The following is a description of a gene set: Mouse Gene Set: GOBP_GLOMERULAR_EPITHELIUM_DEVELOPMENT The process whose specific outcome is the progression of the glomerular epithelium over time, from its formation to the mature structure. The glomerular epithelium is an epithelial tissue that covers the outer surfaces of the glomerulus. The glomerular epithelium consists of both parietal and visceral epithelium. Metanephric glomerular parietal epithelial cells are specialized epithelial cells that form tight junctions as a barrier to protein transport. A metanephric glomerular visceral epithelial cell is a specialized epithelial cell that contains 'feet' that interdigitate with the 'feet' of other glomerular epithelial cells in the metanephros. species: Mus musculus, and this is the list of marker genes: Basp1, Prom1, Pdgfb, Nphs2, Foxj1, Nphs1, Ext1, Lamb2, Ednra, Cd2ap, Notch2, Podxl, Wt1 (NCBI Gene Id 319408), Klf15, Ampd2, Adipoq, Myo1e, Foxc1, Magi2, Ednrb, Edn1, Ptpro, Cd24a, Cd34, Jag1, Iqgap1, Asxl1, Foxc2